The following is a description of a gene set: Negative regulation of MET activity Human Gene Set: REACTOME_NEGATIVE_REGULATION_OF_MET_ACTIVITY studied in species Homo sapiens, and this is the list of marker genes: HGF, SH3KBP1, SH3GL3, CBL (NCBI Gene Id 867), USP8, HGS, UBC, PTPN1, STAM, UBA52, UBB, SH3GL1, GRB2, MET, LRIG1, RPS27A, PTPRJ, EPS15, SH3GL2, PTPN2, STAM2